Given this list of marker genes XRCC3, PRELID3B, MYO16, ESM1, KRT12, MMEL1, KY, B3GNT8, PSMC2, EPHB3, TOPBP1, TSPAN15, ILDR1, TNFRSF17, KIF15, EPS8, HOMER2, CARMIL3, MLPH, LORICRIN, GJA4, BPIFB1, KLHL1, PAQR3, PALB2, KRTAP26-1 (keratin associated protein 26-1), BBS12, IFITM3 (interferon induced transmembrane protein 3), AHNAK, KIF4A, TMEM165, ZBTB16, ZNF235, TSNAXIP1, FOXI1, DRD4, MIR378A, ALG8, RAD50, AMOTL2, SEMA3A, VPREB1, GTPBP10, POLA1, FLG2 (filaggrin 2), ACTRT3, IL1RAPL2, SHCBP1, EGFL6, CASP3, BRCA2, HLX, WDHD1, TNFAIP6, SHROOM3, FNBP1L, GNG2, TCERG1L, FOXB1, TSPAN4, HPSE, TMEM72, VWCE, TPPP3, SSR2, FUT7, LMTK3, MCTP1, DMPK, RGS9, AADAC, HAT1, TRIM29, MIR370, RAB9B, BLM, GPN1, KCTD8, GEM, ZFYVE9, TRIM72, UPRT, MRE11, C1QL4, MIR380, CER1, AVIL (NCBI Gene Id 80056), KIT, ATP5MC1, HCN1, SYNE2, BCAP29, MYADM, MDM4, EGFR, FMO3, NXNL2, LBX1, MYH1, RAP1A, FREM2, UIMC1, KREMEN2, GMDS, BSX, NGRN, NCAPG, ICA1, TSPAN10, SCN4A, NEK1, ARHGDIG, MAGEA10, ANGPT4, GTSF1L, H2AC8, PLB1, FAM170A, PAFAH1B2 (NCBI Gene Id 5049), RAP2A, PABIR2, INTS4, MTCP1, BATF3, CAMP, CTH, TTK, PELI2, HIGD1B, CRLS1, MFSD14B, USP44, CKAP5, HFM1, SPINT3, CTHRC1, ORAI2, TMCC2 (NCBI Gene Id 9911), LHX9 (NCBI Gene Id 56956), UCHL5, PACRG, DPYD, ADGRF2P (adhesion G protein-coupled receptor F2, pseudogene), KRTAP19-7, ASGR1, NCALD, GABRB2, here is a description of the gene set: from publication Popov A, Driesen J, Abdullah Z, Wickenhauser C, Beyer M, Debey-Pascher S, Saric T, Kummer S, Takikawa O, Domann E, Chakraborty T, Krönke M, Utermöhlen O, Schultze JL (PMID 18802101) Genes down-regulated in dendritic cells: immature versus mature inhibitory treated by prostaglandin E2. studied in species Homo sapiens Myeloid dendritic cells (DC) and macrophages play an important role in pathogen sensing and antimicrobial defense. Recently we demonstrated that infection of human DC with intracellular bacterium Listeria monocytogenes (L.monocytogenes) leads to the induction of the immunoinhibitory enzyme indoleamine 2,3-dioxygenase (Popov et al., J Clin Invest, 2006), while in the previous studies L.monocytogenes infection was associated with a rather stimulatory DC phenotype. To clarify this discrepancy we performed comparative microarray analysis of immature mo-DC (immDC), mature stimulatory mo-DC (matDC) and mature inhibitory DC either stimulated with prostaglandin E2 (PGE2-DC) or infected with L.monocytogenes (infDC). Studying infection of human myeloid DC with Listeria monocytogenes, we found out, that infected DC are modified by the pathogen to express multiple inhibitory molecules, including indoleamine 2,3-dioxygenase (IDO), cyclooxygenase-2, interleukin 10 and CD25, which acts on DC as IL-2 scavenger. All these inhibitory molecules, expressed on regulatory DC (DCreg), are strictly TNF-dependent and are in concert suppressing T-cell responses. Moreover, only DCreg can efficiently control the number of intracellular listeria, mostly by IDO-mediated mechanisms and by other factors, remaining to be identified. Analyzing publicly acessible data of transcriptional changes in DC and macrophages, infected by various pathogens and parasites (GEO, GSE360), we noticed that infection of these cells with Mycobacterium tuberculosis causes transcriptional response, comparable with the one caused by listeria in human DC. In fact, granuloma in tuberculosis and listeriosis in vivo are enriched for myeloid DC and macrophages characterized by regulatory phenotype. In summary, regulatory myeloid DC and macrophages may play a dual role during life-threatening granulomatous infections, such as tuberculosis: on one hand, regulatory myeloid cells promote pathogen containment by efficiently killing intracellular bacteria, on the other hand these cells inhibit granuloma-associated T cells and thereby might be involved in the retention of TNF-controlled granuloma integrity protecting the host from granuloma break-down and pathogen dissemination. Human Gene Set: GSE9946_IMMATURE_VS_PROSTAGLANDINE2_TREATED_MATURE_DC_DN